Given this list of marker genes WNT7B, AQP1, POU3F3, UMOD, PKD1, PKD2, here is a description of the gene set: Human Gene Set: GOBP_METANEPHRIC_LOOP_OF_HENLE_DEVELOPMENT The process whose specific outcome is the progression of the metanephric loop of Henle over time, from its formation to the mature structure. The metanephric loop of Henle is a metanephric nephron tubule that connects the proximal convoluted tubule to the distal convoluted tubule in the metanephros. species: Homo sapiens